Given this list of marker genes RELN, SIX1, PYCARD, MYCL, CD1D, RPRM, SOX2, IGFBP2, ELK3, HEPH, CDKN1C, CSRP2 (NCBI Gene Id 7882), MGP (NCBI Gene Id 4256), CCNE1, MDK, GADD45G, LGALS1, EZR, PDGFA, EPB41L2, FOXG1, IGFBP5, TGFB2, GAS6, here is a description of the gene set: species: Mus musculus Genes up-regulated after Cre-lox knockout of LSD1 in pituitary. Precise control of transcriptional programmes underlying metazoan development is modulated by enzymatically active co-regulatory complexes, coupled with epigenetic strategies. One thing that remains unclear is how specific members of histone modification enzyme families, such as histone methyltransferases and demethylases, are used in vivo to simultaneously orchestrate distinct developmental gene activation and repression programmes. Here, we report that the histone lysine demethylase, LSD1--a component of the CoREST-CtBP co-repressor complex--is required for late cell-lineage determination and differentiation during pituitary organogenesis. LSD1 seems to act primarily on target gene activation programmes, as well as in gene repression programmes, on the basis of recruitment of distinct LSD1-containing co-activator or co-repressor complexes. LSD1-dependent gene repression programmes can be extended late in development with the induced expression of ZEB1, a Krüppel-like repressor that can act as a molecular beacon for recruitment of the LSD1-containing CoREST-CtBP co-repressor complex, causing repression of an additional cohort of genes, such as Gh, which previously required LSD1 for activation. These findings suggest that temporal patterns of expression of specific components of LSD1 complexes modulate gene regulatory programmes in many mammalian organs. Human Gene Set: WANG_LSD1_TARGETS_UP from publication Wang J, Scully K, Zhu X, Cai L, Zhang J, Prefontaine GG, Krones A, Ohgi KA, Zhu P, Garcia-Bassets I, Liu F, Taylor H, Lozach J, Jayes FL, Korach KS, Glass CK, Fu XD, Rosenfeld MG (PMID 17392792)